Given this list of marker genes ITCH, BIRC2, NOD2, MAP2K6, UBE2V1, UBA52 (NCBI Gene Id 7311), MAPK11, TNFAIP3, MAP3K7, CASP2, AAMP, UBC, UBE2N, N, CASP4, UBB, RPS27A, MAPK12 (NCBI Gene Id 6300), MAPK14, TAB1, CASP1, CARD9, BIRC3, IRAK2, CASP9, IRAK1, IKBKB, TAB2, TAB3, CASP8 (caspase 8), NOD1, MAPK13, IKBKG (NCBI Gene Id 8517), CYLD, CHUK, RIPK2, TRAF6, here is a description of the gene set: part of: Nucleotide-binding domain, leucine rich repeat containing receptor (NLR) signaling pathways studied in species Homo sapiens NOD1 is ubiquitously expressed, while NOD2 expression is restricted to monocytes, macrophages, dendritic cells, and intestinal Paneth cells. NOD1 and NOD2 activation induces transcription of immune response genes, predominantly mediated by the proinflammatory transcriptional factor NFkappaB but also by AP-1 and Elk-1. NFkappaB translocates to the nucleus following release from IkappaB proteins. NOD1 and NOD2 signaling involves an interaction between their caspase-recruitment domain (CARD) and the CARD of the kinase RIPK2 (RIP2/RICK). This leads to the activation of the NFkappaB pathway and MAPK pathways.<br>Activated NODs oligomerize via their NACHT domains, inducing physical proximity of RIP2 proteins that is believed to trigger their K63-linked polyubiquitination, facilitating recruitment of the TAK1 complex. RIP2 also recruits NEMO, bringing the TAK1 and IKK complexes into proximity, leading to NF-kappaB activation and activation of MAPK signaling. Recent studies have demonstrated that K63-linked regulatory ubiquitination of RIP2 is essential for the recruitment of TAK1. As observed for toll-like receptor (TLR) signaling, ubiquitination can be removed by the deubiquitinating enzyme A20, thereby dampening NOD1/NOD2-induced NF-kappaB activation. NOD1 and NOD2 both induce K63-linked ubiquitination of RIP2, but NOD2-signaling appears to preferentially utilize the E3 ligase TRAF6, while TRAF2 and TRAF5 were shown to be important for NOD1-mediated signaling. In both cases, activation of NF-kappaB results in the upregulated transcription and production of inflammatory mediators. Reactome Pathway: NOD1/2 Signaling Pathway